Given this list of marker genes TALDO1, here is a description of the gene set: Reactome Pathway: TALDO1 deficiency: failed conversion of  Fru(6)P, E4P to SH7P, GA3P Mutations in transaldolase 1 (TALDO1), an enzyme of the pentose phosphate pathway that normally mediates the reversible interconversion of D-fructose 6-phosphate and D-erythrose 4-phosphate to form sedoheptulose 7-phosphate and D-glyceraldehyde 3-phosphate, have been associated with congenital liver disease. part of: Pentose phosphate pathway disease species: Homo sapiens